Given this list of marker genes Dctn6, Dctn2, Actr1b, Actr1a, Dctn3, Actr10, Dctn5, Dctn4, here is a description of the gene set: species: Mus musculus A 20S multiprotein assembly of total mass about 1.2 MDa that activates dynein-based activity in vivo. A large structural component of the complex is an actin-like 40 nm filament composed of actin-related protein, to which other components attach. Mouse Gene Set: GOCC_DYNACTIN_COMPLEX